The following is a description of a gene set: Human Gene Set: GOBP_SMOOTH_MUSCLE_CONTRACTION A process in which force is generated within smooth muscle tissue, resulting in a change in muscle geometry. Force generation involves a chemo-mechanical energy conversion step that is carried out by the actin/myosin complex activity, which generates force through ATP hydrolysis. Smooth muscle differs from striated muscle in the much higher actin/myosin ratio, the absence of conspicuous sarcomeres and the ability to contract to a much smaller fraction of its resting length. species: Homo sapiens, and this is the list of marker genes: ACTA2, EDN1, NMUR1, HTR7, TPCN2, SMTN, SPHK1, CNN1, RAP1GDS1, ZDHHC21, DRD1, PIK3C2A, ITGA2 (NCBI Gene Id 3673), NMUR2, APBB2, NEUROG1, SETD3, P2RX1, PROK2, NMU, CAV1, ADRA2A, ATP2B1, BDKRB2, ADA, GHRL (ghrelin and obestatin prepropeptide), EDN3, TRPA1, MIR145, EDNRA, CHRNB4, ADORA2B, F2R, ADRB2, STUB1, GRIP2, EDNRB, ATP2B4, SULF1, FKBP1B, TBX2, KCNB2, BBS2, CHRM3, NPNT, KCNMA1, ATP1A2, GPER1, CALCA, EDN2, IRAG1, TACR1, TACR3, ADRA2B, TIFAB, CHRM2, SOD1, ROCK1, MYOCD (myocardin), KIT, PRKG1, CTTN, ORMDL3, GDNF, HTR1D, PTGER3, NPY2R, CHRNA3, SRF, ABAT, SLC8A1, P2RX3, COMP, P2RX2, GHSR, ROCK2, DCANP1, SULF2, MIR143 (microRNA 143), DAPK3, HTR2B, ARHGAP42, TNNI3, SPX, RGS2, MIR21, MKKS, OXT, MIR153-1, APBB1, DLG1, GUCY1A1, DOCK4, RHOA, TRPV1, SCN11A, TBX3, TBXA2R, CHRNB2, SCNN1B, ADRA1A, DOCK5, TACR2, MYLK, CD38, DRD2, ADRA2C, HTR2A, MYH11, MAP2K1 (mitogen-activated protein kinase kinase 1)